The following is a description of a gene set: Human Gene Set: GOCC_VACUOLAR_MEMBRANE The lipid bilayer surrounding the vacuole and separating its contents from the cytoplasm of the cell. species: Homo sapiens, and this is the list of marker genes: VPS16, DRAM2 (DNA damage regulated autophagy modulator 2), TMEM59, SLC38A7, MTMR2, CYBRD1, VPS18, DTX3L, ANPEP, VMP1, SLC36A4, COL6A1, ATG14, RAB44, SLC37A3, HPSE, LITAF, CLN3, NSF, ANKFY1, OCLN, IRGM, ARRB1, ENTPD4, LRRC8A, GFAP (glial fibrillary acidic protein), STARD3NL, LRRC8E, VPS13A, TECPR1, TMEM63B, KIF5B, SLC36A2, GDAP2, KCNK6, GLMP, SLC7A14, CLCN5, TPCN1, RNF152, GAA, SLC49A4, TLR3 (toll like receptor 3), SCARB2, ATP6AP1, LAMTOR3, HGSNAT, RAB30, LRP2, SLC2A8, MAP1LC3B, HLA-F, SLC11A2, TMEM199, VAMP7, SLC66A1, LAPTM5 (lysosomal protein transmembrane 5), TEX264, MITF, GIMAP5, PLD1, TMEM63C, ABCC11, PI4K2A, HLA-DRB4, LAMP2, TFE3, RNASEK, MAP1LC3B2, ATP6V0A2, LRP1, SLCO4C1, CLN5, SNAP29, RRAGD, B2M, SCARB1, HLA-DRA, CFTR, ATP6V1F, GPR137B, CD164, SLC3A2, RDH14 (retinol dehydrogenase 14), HLA-DOA, MEAK7, CPNE3, CKAP4, HLA-DPA1, VPS39, SPNS1, MAP1LC3A, HLA-DRB3, ATRAID, TMEM106B, CEACAM8, SIDT2, SEH1L, CYB561, CCZ1, TMBIM1 (NCBI Gene Id 64114), ATXN3, MARCHF2, RNF13, IFITM2, TMEM150B, CHMP7, HLA-DQB1, LAMP1 (lysosomal associated membrane protein 1), VAC14, CHMP1A, FPR1, NPRL3, SLC66A1LP, ATP6V0A1, LRBA, CHMP1B, ATP6V1B2, LAMTOR4, KPTN, CMTM6, DDOST, EVA1A, ABCA3, HLA-DPB1, TM9SF1, LAPTM4B, GOPC, RILP, SLC12A9, ATP6V1D, ATP6V1G1, ATP6V0E1, PRMT1, MCOLN1 (mucolipin TRP cation channel 1), RAB14, AP1S1, ATG16L1, ITM2C, BST2, CLCN7, LAMTOR1, SLC46A3, VPS33B, TLR9, MREG, SLC2A6, CHMP2B, TMEM63A, SNX14, TMEM30A, TM6SF1, SLC11A1, CLEC16A, VPS33A, TSC2, STX17, ATP6AP2, TMEM165, TMEM79, SLC48A1, GNAI1, ATP11B, ATP6V1C2, ATG4B (NCBI Gene Id 29918), FNIP1, MCOLN3, AP1G1, HPS6, TFEB, PLEKHF1, LAMTOR2, RAB39A, GABARAPL1, AP2A1, WDR11, CLCN6, OCA2, TASL, ATP13A2, HLA-H, AP1S2, ATP8A1, SH3GLB1, PLA2G4E, STING1, FNIP2, AHNAK, CLEC10A, VAMP1, SLC39A14, SLC31A2, ABCD4, ENPP1, VPS13B, CD1B, TLR7, C3AR1, RNF167, NEU1, KLC2, MMD (NCBI Gene Id 23531), MAPKAP1, RICTOR, ABCA5, WDR41, FCMR, P2RX4, STARD3, SESN2, SPHK2, SAR1A, BLOC1S1, SLC36A3, ATP6V1A, PIP4P2, RAB7A, MFSD8, MIOS, LITAFD (NCBI Gene Id 101930345), LAMP5, ATP6V0D1, HLA-DMA, SYT11, SLC39A8, THBD, TOM1, LYN, RMC1, SZT2, RAB2B, CSF3R, KICS2, BORCS5 (NCBI Gene Id 118426), HLA-DOB, HSPA8, SLC17A5, GNAQ, MAGT1, GNB4, STK11IP, FLOT1, AP1S3, TAB2, ELAPOR1, WDR59, B4GALT1 (NCBI Gene Id 2683), TRPM2, SLC36A1, ATP11A, AP2M1, AP3D1, TMEM192, DEPTOR, GPR137, ABCB6, AP1M1, AZU1, SPPL2C, SEC13, RRAGA, SLC22A17, TSC1, UVRAG, TBC1D7, ULK1, GPLD1, SLC7A5, MARCHF1, MANBA, GPR137C, ATP6V1B1, AP3B1, AP1B1, ZNRF2, VLDLR, HLA-DMB, CLTA, PSEN1, LNPEP, SNAPIN, PPT1, SYNGR1, AP5M1, MGST1, ATP6V0E2, MYO6, AP2S1 (NCBI Gene Id 9161), WDR24, MLST8, GRN, RHEB, IFITM1 (interferon induced transmembrane protein 1), MFSD12, TMEM150C, SPPL2B, MYL11, PLEKHM2, HLA-DQB2, ACP3, CTSD, CTNS, ATG9A, ARL8A, GNAI3, ENPEP, RPTOR, DAGLB, UBA52, ATP6V1G3, VNN1, TMEM45B, AP2B1, GPR155, VPS35, AP3M1, TCIRG1, EEF1A1, AP2A2, TPCN2, PLEKHM1, VOPP1 (VOPP1 WW domain binding protein), ATP6V1H, ATG12, MARCHF8 (membrane associated ring-CH-type finger 8), STX7, ABCD1, CUBN, ATP6V0C, PGAP6, SLC17A9, HLA-DQA2, PCSK9 (proprotein convertase subtilisin/kexin type 9), PIGR, TMEM138, TMEM175, SLC30A3, PSAP, ABCA2, PIP4P1, DNAJC5, ATP6V0B, ATP6V1E1, KXD1, WIPI1, BRI3, YWHAB, IRAG2, DNAJC13, SORT1, CALCOCO2, ZFYVE26, RAB3D, SLC35F6, SPG11, LDLR, NDUFC2, BLOC1S2, NFAM1, TM4SF19, JMY, RUBCNL, DEPDC5, SBF2, CHMP3, CLCN3, SLC29A3, ANXA2, VPS41, CCDC115, TMEM9, ATP6V1G2, RNF183, ABCA13, BORCS8, EGF, LAPTM4A (NCBI Gene Id 9741), NPRL2, CD1D, CEACAM6 (CEA cell adhesion molecule 6), SLC44A2, CHMP4A, CLCN4, TMEM163, FFAR4, OSTM1, ABCC10, STOM, GLIPR1, SLC26A11, MAP1LC3C, FLCN, UBA1, RAB5C, LMBRD1, GPR143, PLAAT3, VPS11, NCSTN, CHMP4C, MROH1, TRIM23, MARCHF9, TMEM74, RAB37, ATP6V0A4, HLA-DRB1, SLC30A2, ITFG2, TSPAN1, ABCB9, VTI1B, NEU3, CP, EEF1A2, SPAAR, RAB2A, SURF4, PRKD1, CLTC, SLC38A9, MCOLN2, RRAGB, NPC1, RAP1B, M6PR, AP5S1, CYB561A3, ATP6V0D2, ATP10B, CD68, TMEM9B, SPAG9, ATP11C, MTOR, BORCS7, UBXN6, PRCP, CTSA, TM4SF5, CPNE1, RRAGC, DAB2, SPPL2A, DPP4 (NCBI Gene Id 1803), ABHD6, NAPG, TMEM179B, LPCAT1, VPS4A, ECE1, CHMP4BP1, GABARAP, CCZ1B, CHMP5, SYT7, BORCS6, SAR1B, VASN, RAB12, CHMP4B, LAMP3, GNB2, ARL8B, GABARAPL2, SVIP, VAPA, MPEG1, MINAR2, IFITM3, HLA-DRB5, WDFY3, CD74, ANXA6, TLR8, CHMP6, SLC15A4, MYO7A, PLD3, AP1M2, SLC30A4, CDIP1, SLC15A3, NKG7, WDR81, LAMTOR5, TRAF3IP3, CHMP2A, ACP2, RB1CC1, SLC12A4, CD63, GNB1, SLC3A1, GNA11, TMEM203, ATP6V1C1, GBA1, AP5B1, RAB24, VPS13C, VAMP8, MFSD1, HLA-DQA1, HPS4, GABARAPL3, DRAM1